The following is a description of a gene set: species: Mus musculus Nuclear events mediated by NFE2L2 Mouse Gene Set: REACTOME_NUCLEAR_EVENTS_MEDIATED_BY_NFE2L2, and this is the list of marker genes: Psmc6, Psmd13, Psmc1, Ep300, Psma2, Psmd7, Nfe2l2, Psmb7, Psmb5, Skp1, Psmc5, Psmb6, Psmd12, Psma4, Psma6, Prkaa2, Psmc4, Psmd2, Gsk3b, Psmd1, Prdx1 (peroxiredoxin 1), Psmd8, Psmb1, Psma7, Psma1, Psmb4, Psmb2, Psma5, Psmd3, Rbx1, Psmd14 (proteasome (prosome, macropain) 26S subunit, non-ATPase, 14), Psma3, Psmd11, Psmd6, Uba52, Psmb3, Psmc3, Cul1, Rps27a, Ubb, Srxn1, Uba52rt, Adrm1, Psmc2, Ubc